The following is a description of a gene set: Any process that activates or increases the frequency, rate or extent of protein localization to plasma membrane. Human Gene Set: GOBP_POSITIVE_REGULATION_OF_PROTEIN_LOCALIZATION_TO_PLASMA_MEMBRANE studied in species Homo sapiens, and this is the list of marker genes: ZDHHC8, IFNG, PPP1R9B, ANXA13, WNT3A, RER1, ITGB1, AKAP5, EPHA3, PTPN9, PRKCE, CNST, STX3, TNF, ATP2B4, RAMP3, RAB11A, PLS1, PKP1, PRKCI, CIB1, RACK1, EZR, PRKCH, WNK3, NRXN1, ARF6, LRP1, TREM2, COMMD1, RAB11FIP2, ATP2C1, ZDHHC2, PIK3R1, ITGA3, EPHA2, EPHB2, PDPK1, AKT1, STAC2, MIR223, LGALS3 (NCBI Gene Id 81625), CNPY4, SPTBN1, PGRMC1, GPER1, SQSTM1, ZDHHC5, ARHGEF16, ACSL3, VIL1, CLN3, SORBS1, KIF5B, RANGRF, DLG1, STAC, EGFR, RHOG, CLIP3, NKD2, AGR2, STAC3, STX4, DPP10, PRNP